The following is a description of a gene set: Genes down-regulated in comparison of untreated wild type macrophages at 1 h versus those from IRAK4 deficient mice treated with LPS (TLR4 agonist) at 1 h. IRAK-4 is an essential component of the signal transduction complex downstream of the IL-1- and Toll-like receptors. Though regarded as the first kinase in the signaling cascade, the role of IRAK-4 kinase activity versus its scaffold function is still controversial. In order to investigate the role of IRAK-4 kinase function in vivo, ‘knock-in’ mice were generated by replacing the wild type IRAK-4 gene with a mutant gene encoding kinase deficient IRAK-4 protein (IRAK-4 KD). Analysis of bone marrow macrophages obtained from WT and IRAK-4 KD mice with a number of experimental techniques demonstrated that the IRAK-4 KD cells greatly lack responsiveness to stimulation with the Toll-like receptor 4 (TLR4) agonist LPS. One of the techniques used, microarray analysis, identified IRAK-4 kinase-dependent LPS response genes and revealed that the induction of LPS-responsive mRNAs was largely ablated in IRAK-4 KD cells. In summary, our results suggest that IRAK-4 kinase activity plays a critical role in TLR4-mediated induction of inflammatory responses. Human Gene Set: GSE9037_WT_VS_IRAK4_KO_LPS_1H_STIM_BMDM_DN from publication Koziczak-Holbro M, Glück A, Tschopp C, Mathison JC, Gram H (PMID 18266302) species: Homo sapiens, and this is the list of marker genes: IRAG1, CDKN1A, RSAD2, NUDT14, PPP2R5A, S100A1, OR7C1, SLC18A2, SLC38A10, CDH4, CSF2RA, SLFN5, FPR1, MTCP1, ARHGAP18, PTTG1, DNAJC9, LELP1, FAM227B, PALS2, ACE, LAMTOR4, CPLX2, LMOD3, EVA1C, SLC25A3, CBLN4, CD300LD, RPL35, PDCL3, CRELD2, E2F8, SMYD1, GRM4, FAM217B (family with sequence similarity 217 member B), ARHGEF26, USP49, TEAD4, TEX30, DTX1, ST3GAL6, KLF9, TYMS, ARVCF, TNFRSF21, TPSB2, PRSS44P, CCNE1, RTP4 (receptor transporter protein 4), ZWILCH, MPP7, FASTKD3, CDH26, IFI44, RPL23A, TMEM18, SNX5, MAB21L3, EPGN, NMT2, FXYD2, STAP1, PTRH2, SPINK4 (NCBI Gene Id 27290), WNT9A, KIF2C, STOML3, DCUN1D2 (NCBI Gene Id 56234), ANKH, TEP1, LY6E, NFATC2, THBS4, BABAM2, MFHAS1, SCRN3, CASP3 (caspase 3), NME8, VSIG10L, PBK, SUN2, H2AJ (H2A.J histone), ASPN (NCBI Gene Id 54829), AFDN, MGP, RARG, MFSD4A, TPGS2, RPH3AL, SOX5, CLXN, SNUPN, LONRF3, FAM110C, TRPC5, FCGRT, CHRNB4, ZNF628, OTX2, AP1S2, CDKN3, STPG3, PIGR, LY86, HAP1, TAGLN3, IFITM10, S100A8, KIAA1549L, ISOC1, PCK2, ARHGEF19, ANTXR2, GSDMC, DIPK1A, ALKBH1, DNAJC6, ACVR2B (NCBI Gene Id 93), INSM1, REM2, RRH, NSD2, ZBTB3, AKT3, EIF4B, ATP6V0D2, CNOT11, GAST (gastrin), SLC22A9, VWA3A, ZDBF2, PGK2, SEC61A1, IGF1, HTRA2, IL22, ATP2C2, IRX4, IL17RB (NCBI Gene Id 55540), FBXO41, TTK, UCP2, KBTBD8, AHSA1, GGT6, DNPEP, SLC2A8, MUSTN1, TSNAXIP1, ZNF239, A2M, GMNN, ADAM8, BARHL2, ZNF169, DHRS3, RAC1, FRZB, PTCHD3, ALPG, CCR5, RASA4, TTLL9, IFI27L2 (NCBI Gene Id 83982), COL4A6, RPRML, GABRB1, UPK2, PRPF40B, RENBP, RIMBP3C, TMEM114, ITM2A, PRKG2, TATDN1, TRIM44 (tripartite motif containing 44), SPP1, SMC2, SLAMF9, SGK3, NAALAD2, ELN (NCBI Gene Id 2006), DCSTAMP, FAM167B, BHMT2, MRPL48, TEX13B, USP29, KLHL1, OCA2, SVIL, ACSM1, NAP1L2, HCAR1, RADIL, DAB1, F2RL2, TSPAN5, PARP14, SLC25A6 (NCBI Gene Id 8283)